The following is a description of a gene set: The initial attachment of a vesicle membrane to a target membrane, mediated by proteins protruding from the membrane of the vesicle and the target membrane, that contributes to exocytosis. Mouse Gene Set: GOBP_VESICLE_DOCKING_INVOLVED_IN_EXOCYTOSIS species: Mus musculus, and this is the list of marker genes: Exoc1, Rab8a, Unc13c, Exoc8, Stxbp3, Ncam1, Exoc5, Ctbp2, Septin5, Tprg1l (transformation related protein 63 regulated 1 like), Stx1b (syntaxin 1B), Stxbp1, Rims1, Exoc3, Cftr, Rims3, Stxbp2, Vps11, Exoc4, Stx4a, Syde1, Bloc1s6, Kcnb1, Camk2a, Exoc2, Exoc6, Rims2, Ralb, Unc13a, Exoc6b, Plek, Vps18 (VPS18 CORVET/HOPS core subunit), Exoc7, Unc13b, Ykt6, Gnao1, Ppfia3, Vamp2, Sytl2